The following is a description of a gene set: Human Gene Set: TATA_C species: Homo sapiens Genes having at least one occurrence of the motif NCTATAAAAR in the regions spanning 4 kb centered on their transcription starting sites. This matches the TAF, TATA transcription factor binding site V$TATA_C (v7.4 TRANSFAC)., and this is the list of marker genes: PRPF4, OLIG2, FAM53C, AMY2A, MAPRE1, RBP2, VANGL1, NEDD4, OTP, FOXG1, GPRC5D, FAM110D, SLC12A2, TWIST1, HOXD9, KCNJ8, GCH1, BNIP3, KRT25, RHOA, PDHA2, ELMO3, NPY, EEF2, CCN1, AZIN1, WSB2 (NCBI Gene Id 55884), PKIA, CIPC, NRAP, VIP, PRMT3 (protein arginine methyltransferase 3), KAT6A, H3-3B, CD24, CD109, DUOXA2, MYH3, MYO18A, MYL1, PHEX, MYH2, DUOX2, BPIFA1, NAV3, SHANK2, EHF, SLIT3, RASL11B, TGFB3, HOXB6, SATB1, NOL12, HMGN2, BCL11B, SOX5, PDGFRB, GADD45G, MYL2, ESR2, MYH11, ESRRG, TRPC4, DIO2, IL22, MMP3, UCKL1, LPL, PRKAG1, FOXP3, HNF4G, CHMP1B, ELAVL2, CTNNA3, RBFOX1, LAPTM5, PANK1, BDNF, STK39, BACH1, TGFB2, PPP1R12A (protein phosphatase 1 regulatory subunit 12A), PITX2, S100G, COL1A1 (NCBI Gene Id 4970), NFATC2, FBXL22, RAB33A, PPARGC1B, TCTA, CUEDC2, CYB561D2, RAB5B, PACSIN3, NOX3, CALCOCO1, PA2G4, ARRDC3, PDYN (prodynorphin), EIF4A2, PLA2G4B, LOX, LEAP2, SRPK2, CAPN6, RAB15, CITED1, ACTB, TAGLN, GEN1, SLITRK1, NPPA, WDR20, INVS, HIVEP1, CHD2, CRABP2, MYH1, ATP6V1G3, OTUB1, CCDC60, LMOD1, MRPS18B, PLPP1, AKAP12, ORAI3, HOXB9, SVIL, AGPAT4, TSHB, MYCT1, HOXD10, SIM1, TGFBR1, CEP95 (NCBI Gene Id 90799), HOXC5, ATOH1 (NCBI Gene Id 474), PRDM1, NR5A2, NEUROD1, UBE2F, TBX3, TAF7L, TSHZ1, OLIG3, IL17F, HOXB4, RFX4, TLE3, SSBP3, TOB1, PPP2R5E, ERRFI1, STC1, IGSF9B, NKX2-5, ANXA1, NKX6-1, METAP1, LMO2, BARHL1, JARID2, EPC1, FGFBP3 (NCBI Gene Id 143282), GRM2, GJA5, PBX1, CRNN, S100A10, AQP8, VSTM2L, MECOM, MMP10, LTBP1, IL1RAPL1, CCDC85B, HS3ST4, CA2, OTUB2, GRK5, LDB2, PURA, BIN1, LCE5A, DDX5, KITLG, FOXP1, UBR4, HPSE2, CCDC91, PPM1E, EPAS1 (endothelial PAS domain protein 1), COL8A1, NSMCE3, KRT26, PPP1R10, SNRPF, EGF, CDC26, HNRNPA0, GTF2A1L, ATF3, PRKAR2B, CCR7, NAALADL2, H3-4, MYLK (NCBI Gene Id 50483), JUND, GPR50, ALDOB, HOXC6, BMI1, CTDSP1, FSHB, AAK1, EYA1, ASB5, ADTRP, AMDHD1, MT3, CDC42EP2, KCNA3, TOPBP1, HSD17B8, HOXA10, SEMA3A, HAS2, SHISA6, HOXA9, MMP20, MYH4, HAMP, HIVEP3, CCDC38, HOXB8, MAPK10 (mitogen-activated protein kinase 10), JPT2, KRTAP9-2, SLITRK2, TICRR, CAVIN2, OR6C3, DKK2, GTF3C1, CCL7 (NCBI Gene Id 6354), ABCA1, CD96, ITGB1BP2, ARHGEF2, SRF, SREK1, GNAZ, SLC50A1, RTN1, SETBP1 (NCBI Gene Id 284262), RANBP10, MAF, MKNK1, HERPUD1, KCTD15, OTX2, FGF23, PRDM12, KCNK3, H2AX, IL17A, CDX1, RHOH, CYB561D1, IL1B, HOXC4, MMP13, C12orf42, CRHBP, BMPR1B, FIP1L1, FBXO36, KCNK12, ZC3H10, WDR82, PRDM16, FABP4, TCF4, CFL2, ATP5MC2